The following is a description of a gene set: A developmental defect resulting in an obstructing membrane in the posterior male urethra. studied in species Homo sapiens Human Gene Set: HP_CONGENITAL_POSTERIOR_URETHRAL_VALVE Congenital posterior urethral valve, and this is the list of marker genes: SRCAP, NSD1, HNRNPH1, CHRM3, MID1, APC2, BNC2, IGF2